Given this list of marker genes SFI1, ODF2, DYNLT5, MEF2C, IFT25, WDR19, PPARA, PRKAG3, IFT56, PCM1, CEP41, BBS4, C2CD3, WDR35, CEP192, DYNLL1, CEP70, ASAP1, IQCB1, NCOR1, IFT74, BBS1, CEP63, MT-ATP6, CDK1, CCP110, TWNK, TFAM, TUBA3E, HDAC3, TUBB8, TFB1M (NCBI Gene Id 51106), DYNLL2, TUBB1, CCT2, IFT80, CSNK1D, TUBA4A, EXOC2, PLK1, DYNC2I2, TUBB2A, CRTC1, ATP5F1B, CEP43, HAUS5, ATP5F1E, DYNLRB1, BBS9, HAUS3, TFB2M, TUBA3C, PKD1, NPHP3, DCTN3, IFT172, NCOA2, RPGRIP1L, DYNC2LI1, SOD2, GABPA, TUBB6, EXOC5, TUBAL3, IFT57, MICOS13, PRKAB2, CHD9, NINL, DMAC2L, MAPRE1, IMMT, PRKAB1, BBS5, SEPTIN2, CHCHD6, ATP5PO, TUBB2B, DYNLT2B, B9D1, APOOL, DYNC1I2, CEP89, CHCHD3, IFT70A, NRF1, PAFAH1B1, KIF3C, GBF1, TUBB4A, DYNC1H1, BBS2, TUBA1C, HAUS4, MT-ATP8, EXOC1, CCT3, DYNLRB2, SDCCAG8, PRKAR2B, CEP135, MAPK12, B9D2, GABPB1, CCT5 (chaperonin containing TCP1 subunit 5), ESRRA, SSNA1, CRTC2, IFT27, HAUS7, ATP5PF, CEP76, IFT70B, CEP250, OFD1, EXOC6, PPP2R1A, RAB3IP (RAB3A interacting protein), NCOA6, CC2D2A, CLASP1, TGS1, TUBA8, MARK4, CEP78, CARM1, MTX2, IFT46, CEP57, CEP72, HSP90AA1, PRKAG2, SAMM50, AKAP9, ATP5MC2, ATP5MG, ATP5MF, PDE6D, TMEM67, CEP290, CAMK4, HAUS2, CEP164, CEP152, PPARGC1A, HDAC6, MCHR1, CEP97, CNGB1, CLUAP1, PLK4, CRTC3, AHI1, UNC119B, MTX1, IFT81, MICOS10, RXRA, SIRT5, TUBB4B, DNAJC11, HAUS8, PRKAG1, TRIP11, IFT20, RAB11A, DYNC2I1, TCTN2, BBIP1, ATP5MK, KIFAP3, IFT43, PRKACA, RAB8A, CALM1 (NCBI Gene Id 801), MEF2D, TBL1XR1, GLUD2, TCTN3, KIF3B, TCTN1 (tectonic family member 1), NPHP4, CNGA2, ATP5MC3, TUBB, TUBB3, PCNT, CCT8, HAUS1, KIF24, MAPK14, MKS1, CYS1, IFT22, TUBA3D, ATP5F1D, TTC21B, SMO, RP2, ATAT1, YWHAG, RHO, TUBG1, TTC8, ATP5PB, ARL3, BBS10 (Bardet-Biedl syndrome 10), EXOC3, NEDD1, PKD2, APOO, IFT52, NR1D1, CNGA4, KIF17, TMEM216, CEP83, ALMS1, ALAS1, MAPK11, CETN2, ARL13B (ADP ribosylation factor like GTPase 13B), CEP131, CNTRL, TCP1, NEK2, HAUS6, IFT88, PPRC1, PRKAA2, CEP162, SCLT1, CREB1 (cAMP responsive element binding protein 1), TNPO1, PPARGC1B, TUBA1A, ATF2, ACTR1A, HELZ2, NDE1, RAB11FIP3, CREBBP, SIRT3, ARF4, LZTFL1, USP46, POLRMT, ACSS2, YWHAE, ATP5MJ, CENPJ, ATP5MC1, NCOA1, IFT122, ATP5F1C, DYNLT2, GLUD1, CSNK1E, CCT4, FBF1, CYCS, CKAP5, SIRT4, ATP5F1A, DYNC2H1, ARL6, EXOC7, EXOC4, DCTN2, BBS12, TRAF3IP1, INPP5E, IDH2, HSPA9, TBL1X, SSTR3, SSBP1, TTBK2, KIF3A, TUBA1B, DCTN1, POLG2, TUBB8B, MED1, CDK5RAP2, EXOC8, MTERF1, MKKS, ATP5PD, NPHP1, IFT140, ATP5ME, PERM1, HCFC1, SMARCD3, BBS7, TMEM11, here is a description of the gene set: species: Homo sapiens Human Gene Set: REACTOME_ORGANELLE_BIOGENESIS_AND_MAINTENANCE Organelle biogenesis and maintenance